The following is a description of a gene set: Binding to a C-C chemokine; C-C chemokines do not have an amino acid between the first two cysteines of the characteristic four-cysteine motif. Human Gene Set: GOMF_C_C_CHEMOKINE_BINDING studied in species Homo sapiens, and this is the list of marker genes: CXCR2, CCR2, CCR5, CXCR4, ACKR3, CXCR1, XCR1, CCR4, CCR9, ZFP36, CXCR3, ACKR1, CXCR6, CCR6, ACKR4, CX3CR1, CCR10, CCR1, CCRL2, CXCR5, ACKR2, CCR8, CCR7, CCR3